The following is a description of a gene set: Human Gene Set: GOBP_CELL_PROJECTION_ASSEMBLY species: Homo sapiens Formation of a prolongation or process extending from a cell, e.g. a flagellum or axon., and this is the list of marker genes: DNAH8, MTSS2, FXYD5, P2RX4, CILK1, FAM161A, CEP162, SH2B1, APC (APC regulator of WNT signaling pathway), MAPK15, IFT56, TOGARAM1, CC2D2A, WDR44, DNAH7, CCNO (NCBI Gene Id 9998), EHD2, CDC14C, CBY1, ABCC4, NPHP3, BRK1, CCDC66, DNAAF1, BIN3, TTC21B, FGD3, TENM1, FGD6, CROCC, SNX10, GALNT11, RP2, DRC7, DNAI2, FSCN1, GDI2, ABLIM1, AVIL, NCK2, NTN1, CFAP91, RSPH4A, CCDC40, AHI1, DCDC2, CCDC63, TBC1D15, PLK4, PIBF1, MAK, KCTD17, CTTN, ATP6V0D1, IFT70B, TBC1D2B, KIF27, STAU2, NME8, DRC1, VDAC3, PRICKLE1, AIF1L, SPAG6, ODF2, PPP1R35, KCNF1, EVI5L, NDEL1, MKS1, CEP135, DYNLT2B, ASAP1, CDKL1, CC2D2B, CFAP119, TBC1D10B, AIF1, CFAP58, IFT27, ZMYND8, RSPH6A, WDPCP, S1PR1, HYLS1, CFAP57, GAP43, AKIRIN1, ATXN10, CFAP410, FOXJ1, PFN2, ESPN, PALM, NCKAP1L (NCBI Gene Id 3071), COBL, TBC1D1, CCDC88A, PCM1, RABGAP1, ARL6, RALA, CEP89, NRXN1, CDC14B, ACTR3, WDR19, P2RY12, DNAAF6, PIP5K1A, SH3BP1 (SH3 domain binding protein 1), TCHP, CFAP157, KIF3A, CELSR2, ITGB1, RAB11FIP3, WDR35, GSK3B, NCK1, HYDIN, ARHGEF4, PRKCD, WRAP73, IFT46, RAB8A, PTPDC1, ITGB4, DNAH2, YIF1B, CFAP53, B9D2, OFD1, RHOQ, ODAD4, DMD, FLNA, PKHD1, PMP22, CCDC42, ODAD2, SYNE2, KIF24, RAP1A, VAV2, VANGL2, CFAP73, CDC42EP1, VAV3, SRF (NCBI Gene Id 6722), CDC42EP3, RCC2, MAPRE1, TSGA10, PIK3CA (NCBI Gene Id 5290), TBC1D14, ENKD1, RILP, DNAJB13, ABL1, MCIDAS, NOTO, IFT20, ADAMTS16, SPEF1, TBC1D22B, IFT140, CYLD (NCBI Gene Id 8010), TMEM216, ATP8B1, ONECUT2, LRRC61, EPS8L1, ABI3, ATP6V1D, STK36, IFT81, EVI5, IQCB1, RHOG, MYO3A, CFAP46, GOLPH3, ARL13B, USP17L2, INPP5E, RAB3IP, ARFIP2, FAM98A, CFAP54, PDGFA, PTPN23, HRAS, TRPM2, TBC1D9B, TEKT1, EMP1, RIPOR2, SPAG16, IFT57, ACTR2, DOCK11, RAB23, PIERCE1, KLF5 (NCBI Gene Id 688), NLGN1, TBC1D31, CCL21, SEPTIN9, CEP350, NHERF1, DZIP1, TBC1D21, CDKL5, DCX, TRIM32, F2RL1, TBC1D3 (TBC1 domain family member 3), BLOC1S6, TWF2 (twinfilin actin binding protein 2), CCDC103, RABL2B (RAB, member of RAS oncogene family like 2B), CIBAR2, NUDCD3, MARK4, PTPRO, RAB11A, ELMOD3 (ELMO domain containing 3), CCDC65, CPLANE2, IFT25, ANO6 (anoctamin 6), SRGAP2, QRICH2, MIR214, PLEK2, UNC119B, ATG5, PPP1R16B, WDR90, RPGRIP1L, TXNDC15, TBC1D24, MYO10, VCL, RAP2B, HDAC6, TPGS1, NDUFAF2, DPYSL3, E2F4, UBE2B, RAC3, DNAH1, TGFB3, IFT80, CDC14A, TCTN2, KIAA0586, CSPG4, ARL3, FAM110C, DISC1, FGD2, MTSS1, RILPL1, INPPL1, BBOF1, DNAAF10, CFAP206, CPLANE1, TBC1D5, DEF8, BBS5, CDC42EP2, HTT, PDCL2, EPS8L3, TMEM67, CEP250, TBC1D30 (NCBI Gene Id 23329), CLN3, TTLL1, NEFH, MYLK, KIAA0753, CYFIP2, GBF1, ARPC2, ZMYND12, DNAAF3, MCRS1, BBS9, RAP2A, CORO1C, C2CD3, CAV1, EMP2, ODAD1, TBC1D19 (NCBI Gene Id 55296), TBC1D13, FBXW8, AGRN, OCRL, CFAP69, TACSTD2, DNAAF8, CEP70, RP1L1, EMP3, TBC1D7 (TBC1 domain family member 7), TBC1D32, NEURL1, STAP1, TTC12 (NCBI Gene Id 54970), NUP85 (NCBI Gene Id 83705), LUZP1, BBS7, CFL1, CD2AP, NRP1, MEIG1, EPS8L2, BAG4 (NCBI Gene Id 9530), FGFR1, CCDC13, DYNLL1, PLA2G3, MACIR, WASF3, CLCN4, CCP110, PFN1, GORAB, KIT, EXOC5, ARAP1, DNM3 (NCBI Gene Id 26052), WNT1, TTBK2 (NCBI Gene Id 26044), LPAR1, CCR7, ARHGAP35, CFAP44, TRAPPC14 (NCBI Gene Id 55262), CCDC159, SH3YL1, RAPGEF6, MIEN1, IFT172, C15orf62, LIMK2, CIBAR1, CFAP161, CDC42EP5, FNBP1L (NCBI Gene Id 54874), LRRC23, ROCK1, AKT1, DNAAF5, PLEKHM1, MYO3B, DNALI1, ARL13A, CEP290, JHY, DNAAF4, TEKT4, RAB8B, VSTM5, RSPH1, CFAP43, ARHGEF6 (Rac/Cdc42 guanine nucleotide exchange factor 6), PIERCE2, TESK1 (testis associated actin remodelling kinase 1), IFT52, SCIN, EHD4, TEKT3, CFAP298, GAS8, RAPGEF2, PARVA, ATAT1, WHAMM, GFY, KCNQ1, WWTR1, DNAI4, SPATA13, RABEP2, DCTN1, RAP2C, ABI2, IFT43, TBC1D2, RSPH9, TMEM231, PARVG, TTYH1, DNAAF2, CAPG, ICAM1, CDC42EP4, CCDC28B, CFAP221, DNHD1, FBF1, KLC3, SRC, TBC1D17, ODF2L, SNAP29, TBC1D10A, ARHGEF26, MAP4, DZIP1L, CYFIP1, FUZ, ENTR1, RFX2, SPACA9, BBS1, IFT22, DNAH5 (dynein axonemal heavy chain 5), CARMIL1, CEP41 (NCBI Gene Id 95681), PLPPR5, DNAAF11, DNAI1, FRMD7, ARHGAP24, TTC39C, CENPJ, CLUAP1, DUSP23 (dual specificity phosphatase 23), BBS10, POC1B, SLIT2, TTLL3, POC1A, FGD1, RHOD, CEP120, SGSM3 (small G protein signaling modulator 3), EHD3, SAXO1, RAB5A, RPGR, RDX, CCL19, AUTS2, CARMIL2, MYH10, PARVB, IQUB, SPAG17, ALPK1, HAP1, RAP1B, DYNC2I2, KIF3B, DAW1 (dynein assembly factor with WD repeats 1), RO60, EZR, TBC1D22A, WASHC1, SRGAP2C, LPAR3, TTLL5, FGD5, WAS, MAP4K4, B9D1, TMEM17, TGFBR1, TMEM138, PODXL, TRAF3IP1, TTC8, SEPTIN7 (septin 7), RPGRIP1, TBC1D20, ZMYND10, CCDC38, DTNBP1, LAMA5, WASF2 (NCBI Gene Id 10163), BBIP1, RP1, TCTN1, TENM2, MINK1, CLRN1, ONECUT1, CAPZB, DNAH17, CNTROB, EPS8, CFAP61, RILPL2, ACTN2, BBS2, MSTN, STK26, RFX4, USP9X, FAM149B1, HOATZ, TAPT1, CEP126, IFT122, CEP97, SPEF2, CDC42, MICALL1 (MICAL like 1), CEP128, CFAP47, CFAP74, INTU, ARHGEF7, ABLIM2, CFAP20, DYNC2I1, CCDC39, CEP19, CDK10, CFAP100, NCKAP1, ANLN, PIK3R1, P2RX7, FBXO24, UBXN10, GK2, MPHOSPH9, PLXNB3, SHTN1 (shootin 1), CCDC57, ERICH3, ELMOD1, SPATA6, NEK1, SPAG1, RFX3, BBS4, DNAL1, TWF1, RAC2, DAAM2, CLXN, DNMBP, DYNC2LI1, CFAP97D1, OCLN, CFAP70, MARCHF7, ARF6, SDCBP, MIR196A1, CEP131, GSN, MTOR, RAC1, RAB17, PCNT, ATMIN, CDH13, KANK1 (NCBI Gene Id 23189), ODAD3, ATG3, USP6NL, STON1, HRG, ARF4, OPHN1, FSIP2, YAP1, SEPTIN2, PLD1, ABLIM3 (actin binding LIM protein family member 3), FMNL3, FGD4, ARMC9, FMR1, RAP1GAP (RAP1 GTPase activating protein), TMEM237, ARMC12, MYO1A, EPHA2, GPM6A, CFAP65, TMEM80, TNIK, IQCG, TEKT5, DMTN, EVL, DYNC2H1, WASL, SCLT1, TEKT2 (NCBI Gene Id 27285), SDCCAG8, ARMC2, HSP90AA1 (heat shock protein 90 alpha family class A member 1), TBC1D8, TTLL8, SSX2IP, MKKS, CCDC15, IFT88, AJUBA, NME5, PLCE1, CCDC146, EHD1, FHDC1, S1PR2, DNAI3, CEP20, B3GLCT, KCNJ10, EPHB2, LRGUK, GMNC (NCBI Gene Id 652527), CEP164, NOTCH1, ARHGAP44, AKAP4, PPP1R9B, RAB1A, FER, WDR11, TBC1D10C, CEP83, RAB34, PFN4, LRRC46, LIMA1, TBC1D16, TCTN3, CFAP184, CSNK1D, MNS1, TMEM107, INPP5K, ABITRAM, IFT74, CFAP263